Given this list of marker genes Cltc, Dnajc6, Gak, Synj1, Hspa8, here is a description of the gene set: Mouse Gene Set: GOBP_CLATHRIN_COAT_DISASSEMBLY species: Mus musculus The disaggregation of a clathrin coat into its constituent components; results in stripping or removing the clathrin coat from clathrin-coated vesicles (CCV) before fusing with their targets. CVVs transport cargo from plasma membrane and trans-Golgi to the endosomal system.